Given this list of marker genes Aqp8, Kcna5, Mip, Abcb11, Abcc2, here is a description of the gene set: studied in species Mus musculus Mouse Gene Set: GOCC_INTRACELLULAR_CANALICULUS An apical plasma membrane part that forms a narrow enfolded luminal membrane channel, lined with numerous microvilli, that appears to extend into the cytoplasm of the cell. A specialized network of intracellular canaliculi is a characteristic feature of parietal cells of the gastric mucosa in vertebrates.